The following is a description of a gene set: Mouse Gene Set: TABULA_MURIS_SENIS_TRACHEA_BASAL_EPITHELIAL_CELL_OF_TRACHEOBRONCHIAL_TREE_AGEING species: Mus musculus from publication Tabula Muris Consortium (PMID 32669714), and this is the list of marker genes: Pxmp2, Eng, Neurl1b, Ccl7, Lyz1, Trir, Tmem181c-ps, Selenow, Rhoc, Tle5, E2f4, Cbr1, Jund, Gadd45gip1, Hspa1a, Bri3, Ddx41, Mcee (methylmalonyl CoA epimerase), Dmkn, Tmem267, Grk3, Tm4sf1